Given this list of marker genes Nr6a1, Eps8, Zfp386, Zfp947, Lmo2, Cpt1a, Lrrc2, Tead1, Gm3985, Dach2, Heatr6 (HEAT repeat containing 6), Rb1cc1, Zfhx3, Pdf, Zrsr2, Zfp458, Mmp8, Pax9, Zfp935 (zinc finger protein 935), Zfx, 4930444P10Rik, Zfp592, P2ry10 (NCBI Gene Id 78826), Rtl4, Dsc3, Abi2, Ctdspl2, Esco1, Trim30a, Igsf10, Camk1, Cd200r1, Sgk3, Kif26a, Ubn2, Psd3, Gnai3, Rims2, Bicd1, Lrrtm2, Lamp2, Arpp19, Cacna1g, Adam10, Huwe1, Zfp735, Cdc40, Gpr141b, Ak5, Slc6a6, Map4k5, Paqr7, Col6a3, Otud7b, Nemf, Fut9, Chrm1, Camsap2, Ctnnd1, Zfp980, Tgfbrap1, Ralyl, Nxph2, Dnase1l1, Ano4, Prom1, Tmprss11f, Eea1, Zc3h12c, Fndc5, Zfp953, Olig2, Maea, Plekha3, Pi15, Rbm39, Marchf6, Fndc3a, Dennd4c, Zfp942, Atoh1 (atonal bHLH transcription factor 1), Sgpp1, D630039A03Rik, Lyplal1, Fam178b, Stox2, Rex2, Hsbp1l1, Cdc37l1, Tmc2, Parva, Zfp1008, Zfp995, Carf, Vgll3, Insig2, Smcr8, Zfp758, Insig1, Zfp945, Slc25a36, Spsb2, Zfp600, Rps6ka2, Lrp6, Nfib, Lilra6 (leukocyte immunoglobulin-like receptor, subfamily A (with TM domain), member 6), Mid2, Igsf5, Pkn2, Zfp493, Fzd10, Mbtd1, Syt4, Tgm6, Hjurp, Cenpf, Lpin2, Pik3ca, Jag1 (jagged 1), Lats2 (large tumor suppressor 2), Mapt, Akirin2 (akirin 2), Slc33a1, Vmp1, Mfap3l, Gpr82, Tnrc6b, Barhl1, Map1b, Orc3, Phf6, Pggt1b, Ppp3cb, Opcml, Acot3, Cfap69, Pate4, Rab27b, Phf20l1, Bcs1l, Rbpj, Reep3, Zbtb34, Arrb1, Nacc2, Tmem181a, Mdga2, Vsig1, Akna, Zfp994, Hoxb4, Lrit1, Tgfb1i1, Mpped2, Jph3, Rida, Tor1aip2, Krtap4-20, Vstm2a, Lamp3, Lin28b, Zfyve26, Rfx3, Zfp820, Tia1, Creg2, Prkaa2, Ywhaz, Ocln, Rc3h1, Bach1, Rab22a, Tbx4, Zfp981, Pak3, Stt3a, Rab21, Morf4l1, Zfp366, Ddr2, Cbfb, Usp25, Zfp936, Il33, Rai2, Sh2d1a, Prom2, Cntn1, Rab23 (RAB23, member RAS oncogene family), Hoxd10, Tnfrsf13c, Pld1, Sbno1, Pak2, Zfp451, Tdrp, Snx1, Tns4, Plxdc2, Dock1, Zfp513, F2r, Drd1, Ranbp10, Dscaml1, Tll1, here is a description of the gene set: Mouse Gene Set: MIR_6377 from publication Chen Y, Wang X (PMID 31504780) Genes predicted to be targets of miRBase v22 microRNA mmu_miR_6377 in miRDB v6.0 with MirTarget v4 prediction scores > 80 (high confidence targets). studied in species Mus musculus